The following is a description of a gene set: Reactome Pathway: Amino acid transport across the plasma membrane Amino acid transport across plasma membranes is critical to the uptake of these molecules from the gut, to their reabsortion in the kidney proximal tubulues, and to their distribution to cells in which they are required for the synthesis of proteins and of amino acid derived small molecules such as neurotransmitters. Physiological studies have defined 18 "systems" that mediate amino acid transport, each characterized by its amino acid substrates, as well as its pH sensitivity and its association (or not) with ion transport. More recently, molecular cloning studies have allowed the identification of the plasma membrane transport proteins that mediate these reactions. Amino acid uptake mediated by 17 of these transporters is annotated here. part of: SLC-mediated transport of amino acids studied in species Homo sapiens, and this is the list of marker genes: SLC7A1, SLC7A5, SLC38A3, SLC7A3, SLC6A6, SLC1A4, SLC6A12, SLC25A29, SLC36A1, SLC6A14, SLC38A4, SLC43A2 (NCBI Gene Id 124935), SLC38A5, SLC7A9, SLC3A2, SLC43A1 (NCBI Gene Id 8501), SLC6A20, SLC7A2 (NCBI Gene Id 6542), SLC36A4, SLC36A2, SLC6A19, SLC38A2, SLC7A6, SLC1A5, SLC6A15, SLC7A8, SLC7A11, SLC7A10 (solute carrier family 7 member 10), SLC16A10, SLC7A7, SLC3A1, SLC38A1